The following is a description of a gene set: from publication Elo LL, Järvenpää H, Tuomela S, Raghav S, Ahlfors H, Laurila K, Gupta B, Lund RJ, Tahvanainen J, Hawkins RD, Oresic M, Lähdesmäki H, Rasool O, Rao KV, Aittokallio T, Lahesmaa R (PMID 20620947) The aim of this dataset was to study in detail the transcription kinetics initiated by cytokine IL-4 in early differentiation of Th2 cells. Genes down-regulated in comparison of CD4 T cells treated with IL4 and anti-IL12 at 6 h versus the untreated cells at 6 h. studied in species Homo sapiens Human Gene Set: GSE17974_IL4_AND_ANTI_IL12_VS_UNTREATED_6H_ACT_CD4_TCELL_DN, and this is the list of marker genes: GPN3, MTUS2-AS1, MBP, C4BPA, TTC7A, SMCHD1, GNAL, SLC27A2, HAP1, GIMAP6, CARD11, AASDH, CEMIP, IRS1, POLR3G, R3HDM1, PDE4D, CNOT6L, SPIN4, TIFA, NOX3, SEPTIN11 (septin 11), LACTB2, GCA, CCDC24 (coiled-coil domain containing 24), IFIT2, KRT12, PLS1, LIF, LRCH1, SAA4, TP53INP1, AHI1, POLR1G, RELL1, SYTL2, EXOSC6, CTNNA1, GK, KLHL15, ABCC4, DNAJC24, SIRPG, TTC33, ARHGAP31, GGACT, HDGF, CAMSAP2, ATP2C1 (NCBI Gene Id 612), SYNM, PHOSPHO2, CRCP, MAP4K5, MTFR1, PFKFB3, CCDC82 (NCBI Gene Id 79780), TCAF2, RHCG, FAM107B, BAZ2B, MED21, STAC2, LRP1B, MFAP4, CCDC18, CCDC32, LUZP1, TMEM51, CCL2, CLIP2, STX11, SOCS2, RIN3, MYOCD, TNFSF13B, LINC00102, LAG3, TMEM117, ZNRF3, TRMT61B, P2RY14, OTUD1, GALNT1, CHRNA6, IFNAR2, ZBTB21, TADA2A (transcriptional adaptor 2A), PAM, CTDP1, CFAP299, H2BC12L, CIART, TGIF1, ARRB1, PYHIN1, USF3, IL6R, NOG, TFPI, LINC02135, ITPR1, IFIT3, EIF4G3, FRK, MAP9, TDRKH, GBP1, DDIT4, PASK, LACC1, GPD2, IPCEF1, SGK1, ERI1, ECE2 (endothelin converting enzyme 2), GBP4, SLC35F2 (solute carrier family 35 member F2), LRRC34, C2CD3, OLMALINC, TLX1 (T cell leukemia homeobox 1), PHACTR3, ZFP36L2, TSGA10, GPRIN3, PPP1R2, KCNK7, ABHD6, HS3ST3B1 (heparan sulfate-glucosamine 3-sulfotransferase 3B1), TLE3, TSC22D2, SAMHD1, MAP3K13, MTERF4, NEDD4, MALT1, FAS (Fas cell surface death receptor), GZMB, PTGS2, COL6A3, FABP5, PDGFA, SGMS1, GPBP1L1, GBP5, TPM4, ATP10A, SAMD5, IL25, LXN, ZNF57, F2RL1, AP5B1, BMP2K, EMP1, SCFD2, TNFSF10, KRT84, ALG14, RUBCNL, IFIT5, NPL, CXCL1, DCAF12L1, PGM2L1, PEA15, ADGRE1, BBIP1, IL1A, TOX2 (TOX high mobility group box family member 2), RB1, CYTH3, PFKM, PLSCR1, RXYLT1, NINJ2, CEMIP2, JUN, ZNRF2P1, MDFIC, IL1B, CREB1, MXI1, HNRNPLL, TMEM38B, TNFSF4, DGKB, DUSP16, WDR48 (NCBI Gene Id 57599), TLR5, ID3, SH3GL1P1, LINC00302 (long intergenic non-protein coding RNA 302), JPH3, IL12A, GIMAP8, KCNJ2